Given this list of marker genes MAPK1, RPS6KA5 (NCBI Gene Id 9252), CXCL8 (C-X-C motif chemokine ligand 8), FGFR3, SRC, E2F1, ARAF, PIK3R2, ERBB2, MMP2 (NCBI Gene Id 4313), CDK4, RB1, PIK3R1, RASSF1, HBEGF, MMP9, EGF, NRAS, DAPK1, DAPK2 (NCBI Gene Id 23604), CDH1, EGFR, UPK3A, MAP2K2, CDKN1A, BRAF, CCND1, MYC, MMP1, MDM2, HRAS, TP53, TYMP, VEGFA, RAF1, KRAS, DAPK3, THBS1, MAP2K1, CDKN2A, here is a description of the gene set: Human Gene Set: WP_BLADDER_CANCER Bladder cancer species: Homo sapiens